The following is a description of a gene set: species: Homo sapiens Human Gene Set: HP_SOCIAL_AND_OCCUPATIONAL_DETERIORATION Social and occupational deterioration, and this is the list of marker genes: APOL4, MTHFR, MAPT, RTN4R (NCBI Gene Id 96184), DAOA, EP300, APOL2, DRD3, SYN2, CREBBP, CHI3L1, COMT, HTR2A, GRIN2A